The following is a description of a gene set: species: Mus musculus Mouse Gene Set: GOCC_DNA_DEPENDENT_PROTEIN_KINASE_COMPLEX A protein complex that is involved in the repair of DNA double-strand breaks and, in mammals, V(D)J recombination events. It consists of the DNA-dependent protein kinase catalytic subunit (DNA-PKcs) and the DNA end-binding heterodimer Ku., and this is the list of marker genes: Xrcc5, Xrcc6, Zbtb7a, Prkdc, Uvrag